The following is a description of a gene set: Mouse Gene Set: GOBP_TRIGLYCERIDE_STORAGE studied in species Mus musculus The process of binding or confining any triester of glycerol such that it is separated from other components of a biological system., and this is the list of marker genes: Lpl, Tnf, Plin5, Osbpl11, Abhd5, Osbpl8, Pparg, Plin2, Trem2, Fitm2, Apoc4, Il1b (NCBI Gene Id 16176), Ppara, Plin3 (NCBI Gene Id 66905), Pnpla2, Enpp1